The following is a description of a gene set: Human Gene Set: ZNF785_TARGET_GENES from publication Yevshin I, Sharipov R, Kolmykov S, Kondrakhin Y, Kolpakov F (PMID 30445619) studied in species Homo sapiens, and this is the list of marker genes: LONP1, APBB3, RIMKLB, TSHZ2, LMF1, LRP3, SMG7-AS1, APOM, KLHDC9, XKR8, PIEZO1, STAT6, THAP9-AS1, CASC3, ZNF571, CBX4, SNX8, JAK2, BCL7C, DCUN1D2, NUSAP1, SMG7, EBF4, NAA60 (N-alpha-acetyltransferase 60, NatF catalytic subunit), BRWD1, CABIN1, TMCO3, GBA1, ZNF790, GPR158, TDRD7, TMEM121B, TXLNA, RPS19, SOX8, TCF4, C19orf73 (chromosome 19 open reading frame 73), DRG2, FCHSD2, C17orf49, CATSPERD, DDX11L10 (DEAD/H-box helicase 11 like 10 (pseudogene)), MAST1, ZNF555, KXD1, GOLGA7, SEC31A, PGAM5, LINC00431, BAG6, ZNF276, CEROX1, DPY19L2P1, KMT5B, LINC01664, RING1, BCL7A, LINC02716, RNF220, ZNF540, ESYT2, VPS9D1, PPFIA3, COMTD1, TMEM248, ZNF10, OSTM1, SLC35A4